Given this list of marker genes GLO1, MKLN1, PDK4, PKM (NCBI Gene Id 8127), PDP1, ME2, DLAT, MPC2, WDR26, LDHAL6A, GID8, GPT, VDAC1, ARMC8, MAEA, PGAM5, PDK1, PDP2, PDHA1, PDK2, FAHD1, MPC1L, UBB, RPS27A, PDHX, LDHC, GSTZ1, LDHB, UBC, MPC1, PC, GID4, RMND5A, PDK3, RMND5B, ME1, HAGH, LDHAL6B, LDHA, SIRT4, NEK1, PDHB, DLD, PDPR, PKLR, ME3, PDHA2, UBA52, RANBP9, here is a description of the gene set: part of: Aerobic respiration and respiratory electron transport Pyruvate sits at an intersection of key pathways of energy metabolism. It is the end product of glycolysis and the starting point for gluconeogenesis and can be generated by the transamination of alanine. The pyruvate dehydrogenase complex can convert it to acetyl CoA, which can enter the TCA cycle or serve as the starting point for the syntheses of long-chain fatty acids, steroids, and ketone bodies depending on the tissue and metabolic state in which it is formed. It also plays a central role in balancing the energy needs of various tissues in the body. Under conditions in which oxygen supply is limiting, e.g., in exercising muscle, or in the absence of mitochondria, e.g., in red blood cells, re-oxidation of NADH produced by glycolysis cannot be coupled to the generation of ATP. Instead, re-oxidation is coupled to the reduction of pyruvate to lactate. This lactate is released into the blood and taken up primarily by the liver, where it is oxidized to pyruvate and can be used for gluconeogenesis. For a recent review, see Prochownik & Wang, 2021. studied in species Homo sapiens Reactome Pathway: Pyruvate metabolism